Given this list of marker genes MACROH2A1, CTCF, SMC5, BUB1, CTNNB1, NSMCE2, DDX11, TNKS, AXIN2, NAA10, ATRX, SLF1, WAPL (NCBI Gene Id 23063), RAD21, SFPQ, FEN1 (flap structure-specific endonuclease 1), ESPL1, SLF2, here is a description of the gene set: Human Gene Set: GOBP_REGULATION_OF_SISTER_CHROMATID_COHESION studied in species Homo sapiens Any process that modulates the frequency, rate or extent of sister chromatid cohesion.